The following is a description of a gene set: studied in species Homo sapiens Human Gene Set: GOMF_TRANSMEMBRANE_RECEPTOR_PROTEIN_KINASE_ACTIVITY Combining with a signal and transmitting the signal from one side of the membrane to the other to initiate a change in cell activity by catalysis of the reaction: a protein + ATP = a phosphoprotein + ADP., and this is the list of marker genes: SOSTDC1 (sclerostin domain containing 1), EFNA3, EPHB6, FGFR4, ACVR1B, FGFR1, ALK, TIE1, AXL, PDGFRA, TGFBR3L, MET, EPHA3, HJV, ACVR1, FGFR2, EPHA2, FLT3, FGFR3, NRP2, GREM1, EPHA8, MUSK, ACVR2B, EPGN, MERTK, NRG1, NGF, ACVR1C, FGFRL1, EPHA10, EREG, RYK, EPHA4, TYRO3, ALKAL2, BTC, TEK, HBEGF, IGF1, DDR2, DGKQ, MST1R, CRIM1, NRG3, ERBB2, DDR1, EPHB2, ROS1, EPHA6, IGF1R, EFNA5, FLT1, TGFA, EPHB1, ROR2, FLT4, EPHB4, KDR, AMHR2, EPHA5, ACVRL1 (activin A receptor like type 1), ACVR2A, EGFR, ALKAL1, EFNB3, LILRB4, EPHB3, NRP1, EPHA7, EFEMP1, VEGFA, INSR, EPHA1, LTBP4, INSRR, NTRK1, BMPR1A, TGFBR3, EGF, BMPR2, LTBP1, LTK, TGFBR1, NTRK3, CSF1R, AREG, ANGPT4, PDGFRB, EFNA4, PDGFRL, IGF2R, TGFBR2, ROR1, KIT, ERBB4, NTRK2, RET, IGF2, BMPR1B